The following is a description of a gene set: Any process that stops, prevents, or reduces the frequency, rate or extent of biomineral tissue development, the formation of hard tissues that consist mainly of inorganic compounds. species: Mus musculus Mouse Gene Set: GOBP_NEGATIVE_REGULATION_OF_BIOMINERAL_TISSUE_DEVELOPMENT, and this is the list of marker genes: Hif1a, Grem1, Ltbp3, Rflnb, Nos3, Mepe, Enpp1, Gata1, Ptk2b, Nfe2, Hey2, Sox9, Bcor, Aspn, Fgf23, Trpm4, Hey1, Ccr1l1, Pth, Notch1, Gas6, Rflna, Ahsg (NCBI Gene Id 11625), Srgn, Tgfb1, Ccr1, Ecm1